Given this list of marker genes ADH5, DSTN, CTSF, NENF, FCGRT, MMP2, CCN1, HTRA1, IMPDH2 (NCBI Gene Id 3615), HMGN2, GYPC, SNHG32, RAB34, PALLD, KLHDC2, PDK4, TXNIP, ID2, IGFBP4, TIMP1, TCEAL1, MYLK, CLEC11A, ALDH1A1, CUTA, CRYAB, CYB5A, COL3A1, TALDO1, DNAJB1, COL6A1, LAMP1, SMARCA1, COL6A3, NR4A1, C4orf3, ATP6AP2, ST3GAL4, MAOB, KLHDC8A, TIMP2, PLTP, GADD45B, ARL1, GLUL, EMILIN1, MDK, NFKBIA, PRDX4, HS3ST1, TTC3, IGF1, SLC16A9 (solute carrier family 16 member 9), TAGLN, SMIM7 (NCBI Gene Id 79086), CXCL12, OLFML3, TSPAN4, COL6A2, C7, FKBP7, FKBP10, NUCB2, OS9, HSPA1B, NPC2, HES1, CYB5R3, LTBP4, EGR1, SEPTIN7, NDRG2, SH3BGRL, PEG3, MFAP4, FAM162A, AKR7A2, AK3, IER2, GDI2, EIF3E, SMOC2 (NCBI Gene Id 64094), LHFPL6, SELENOM, PPM1K, LAMP2, SERPINH1, AP3S1, SERPINF1, ACTA2, CAVIN1, PCMTD1, EEF1A1, MGP, ABCA8, CTSD, LGALS1, CELF2, TPM1, SELENOW, PGRMC1, RABAC1, ITM2B, CLDN11, CDH11, AKAP12, VIM (vimentin), ATF3, EIF4A2, CPE, ZFP36L1, LGALS3BP, HSPA6, TPM2, CSRP1, PBX1, TCEAL3, CALD1, TCEAL4, TMEM98, FXYD6, TAX1BP3, ADM (NCBI Gene Id 133), PLPP3, SAT2, CCDC80, IFI27L2, PDGFRA, MYADM, ACTR10, INTS6, ID3, FXYD1, FOS, TMEM50B, KLF4, LUM, ZFP36 (NCBI Gene Id 7538), GPC3, MPST, SPARC, IGFBP5, SSPN, GSN (NCBI Gene Id 2934), ADAMTS1, SPARCL1, GSTM5, NBL1, C12orf57, LRPAP1, NFIC, TENT5A, RNH1, PSAP, GSTM3, NME3, SELENOP, THY1, ECHDC2, PDLIM3, PMP22, TCF21, RHOC (NCBI Gene Id 389), APOE, EPHX1, BNIP3L, EFEMP2, DCN, TUBA1A, OGN (osteoglycin), WASF2, PEBP1, MPHOSPH8, RHOB, CCN5, CIRBP, CCNL1 (NCBI Gene Id 57018), MMP14, HNMT, DDIT4, CALU, CPXM1, COL1A2, SERPING1, FKBP8, DUSP1, GADD45G, LAPTM4A, BSG, SFRP4, ALDH7A1, FN1, NFIA, SNAI2, KDELR1, IER3, ESD, RNASE4, HSPA1A, TPM4, ATRAID, CTSK, CFD, C1S, FOSB, ADISSP, PPIC, NOP53, RWDD4, BDH2, ZFYVE21, JUNB, COLEC11, MEG3, IFITM3, HADHB, COL1A1 (NCBI Gene Id 4970), MMP23B, PDCD4, LGALS3, SYPL1, MATN2, RPLP0, P4HB, REXO2, BNIP3, ING2, MXRA8, VKORC1, RARRES2, ILK (integrin linked kinase), EID1, MORF4L2, BST2, RCN1, NUCB1, TMEM59, PFN2, FSTL1, PLD3, IFI6, CFH, ST13, DEPP1, PDGFRL, SLC40A1, SVIL, OSR2, ALDH9A1, IGFBP3, CEBPD, HEXIM1, SMARCA2, RGS2, CLK1 (NCBI Gene Id 1195), CCNI, SCD5, TMEM230, AEBP1, NR2F2, SERPINB6, TSC22D3, S100A6, ERGIC2, PRELP, TCEAL8, MBNL2, NUCKS1, SCP2 (sterol carrier protein 2), DDAH2, TGFB1I1, HMGN3, SGK1, ARL4D, LEPROT, C1R, SPON2, FBXO21, SOCS3, NDN, QSOX1, SH3BP5, MYL9, CAPZB, KLF10, FBLN1, CYBRD1, PPP1R15A, COL18A1, KCNQ1OT1, LRRC17, KRT19, APP, BGN, ENG, SGCE, CPQ, TMEM176B, BTG2, JUN, here is a description of the gene set: TC from (early atretic) follicle D and present in stromal samples were mainly present in CL2 and CL6 (Fig. 4a, Supplementary Fig. 2c), suggesting that those may represent atretic TC. The TC in CL2 and CL6 expressed IFITM3, lower levels of COL3A1 and higher levels of FOS and IGFBP5 compared to the TC in CL5 (Fig. 8a). from publication Fan X, Bialecka M, Moustakas I, Lam E, Torrens-Juaneda V, Borggreven NV, Trouw L, Louwe LA, Pilgram GSK, Mei H, van der Westerlaken L, Chuva de Sousa Lopes SM (PMID 31320652) species: Homo sapiens Human Gene Set: FAN_OVARY_CL6_PUTATIVE_EARLY_ATRETIC_FOLLICLE_THECAL_CELL_2